Given this list of marker genes CD79B (NCBI Gene Id 974), FCRL5, PAWR, C8G, EBF1, MEG3, PPP1R17, TNFRSF13C, P2RX5, DENND5B, GPR20, NIBAN3, FAM30A, RUBCNL, CFH, VMO1, DOK7, FCRL2, MS4A1, FCER2, L1TD1, BANK1, SETBP1, PCDH9, FCRLA, LINC00926, TSPAN13, CXCR5, CD19, CNR2, LARGE1, FCRL1, MTSS1, CD79A, CD72, RPS26, SYT17, MOXD1, CD22, here is a description of the gene set: species: Homo sapiens Human Gene Set: SOBOLEV_PBMC_PANDEMRIX_AGE_18_64YO_MEDIUM_HIGH_ADVERSE_EVENT_SUBJECTS_1DY_UP Adjuvanted vaccines afford invaluable protection against disease, and the molecular and cellular changes they induce offer direct insight into human immunobiology. Here we show that within 24 h of receiving adjuvanted swine flu vaccine, healthy individuals made expansive, complex molecular and cellular responses that included overt lymphoid as well as myeloid contributions. Unexpectedly, this early response was subtly but significantly different in people older than ~35 years. Wide-ranging adverse clinical events can seriously confound vaccine adoption, but whether there are immunological correlates of these is unknown. Here we identify a molecular signature of adverse events that was commonly associated with an existing B cell phenotype. Thus immunophenotypic variation among healthy humans may be manifest in complex pathophysiological responses. Genes up-regulated in peripheral blood mononuclear cell -7d vs 1d in adults (18-64) (medium/high AE subjects) after exposure to Pandemrix (A/California/7/09 (H1N1)), time point 1D from publication Sobolev O, Binda E, O'Farrell S, Lorenc A, Pradines J, Huang Y, Duffner J, Schulz R, Cason J, Zambon M, Malim MH, Peakman M, Cope A, Capila I, Kaundinya GV, Hayday AC (PMID 26726811)